The following is a description of a gene set: Human Gene Set: WP_EXERCISE_AND_HYPERTROPHY_IN_SKELETAL_MUSCLE Exercise and hypertrophy in skeletal muscle species: Homo sapiens, and this is the list of marker genes: EIF4EBP1 (eukaryotic translation initiation factor 4E binding protein 1), IL1R1, MSTN, CCN1, NR4A3, IFNG, ANKRD1, MYOG, VEGFA, JUND, ZEB1, DUSP14, IL18, EIF4E, WDR1, IL1A, ATF3, HBEGF, IFRD1, ADAM10